Given this list of marker genes JAM3, PECAM1, SIRPA, AZU1 (azurocidin 1), CCR2, AGER, CD47 (NCBI Gene Id 961), MIR146A, JAML, PDGFD, PLCB1, here is a description of the gene set: Human Gene Set: GOBP_MONOCYTE_EXTRAVASATION The migration of a monocyte from the blood vessels into the surrounding tissue. species: Homo sapiens